The following is a description of a gene set: studied in species Homo sapiens Human Gene Set: GSE25088_CTRL_VS_IL4_AND_ROSIGLITAZONE_STIM_MACROPHAGE_UP Genes up-regulated in wildtype bone marrow-derived macrophages: control versus treated with IL4 and rosiglitazone. C57Bl/6 wild-type and STAT6 KO mice were used to study PPARg and IL-4 signaling. Bone marrow of 3 mice per group was isolated and differentiated to macrophages with M-CSF (20 ng/ml). 20 ng/ml IL-4 was used to induce alternative macrophage activation and 1 uM Rosiglitazone (RSG) was used to activate PPARg. From each mouse 4 samples were generated: 1. M-CSF, 2. M-CSF+RSG, 3. IL-4 and 4. IL-4+RSG. All compounds were added throughout the whole differentiation process, and frech media was added every other day. Control cells were treated with vehicle (DMSO:ethanol). After 10 days, RNA was isolated and gene expression profiles were analyzed using Mouse Genome 430 2.0 microarrays from Affymetrix. from publication Szanto A, Balint BL, Nagy ZS, Barta E, Dezso B, Pap A, Szeles L, Poliska S, Oros M, Evans RM, Barak Y, Schwabe J, Nagy L (PMID 21093321), and this is the list of marker genes: RIOX2, CD44, CDCA7, CXCR3, TSPYL4, CD86, MB21D2, ESD, MED26 (NCBI Gene Id 9441), AQP3, GGT1, CHP2, HSD17B11, ELF4, SLC38A2, RDM1, SSBP2, CLDND1, RDX, FYTTD1 (NCBI Gene Id 84248), ARMCX1, TNFRSF11A, GRK2, COMP, DTX4, IL7R, TBCEL, LINC01904 (long intergenic non-protein coding RNA 1904), COTL1, POLR3G, BIVM, MAMDC2, SNCG, KCNQ5, MICAL2, ID1, RARA, DLST, IL17D, IRAK3, PTK7, TCF7 (NCBI Gene Id 6932), NOD2, SIK1, SVIL, SH2D3A, IL6ST, POGLUT2, HLA-DPB2, ANXA2R-AS1, CD2AP, NAPSB, IRF1, IRF2BPL (interferon regulatory factor 2 binding protein like), GPC6, REL, ADAM9, MALT1, GFRA1 (NCBI Gene Id 2674), SELL, TPBG, RGS16, GZMK, LINC03007, RAB5A, OLIG1, DTX1, CACNG8, CASK, RAB21, KLHL6, EXD2, SINHCAF, SNN, SEC24C (NCBI Gene Id 9632), CEP19, IL10RA, QTRT1, KIT, HLA-DMA, GINM1 (NCBI Gene Id 116254), FAIM2, HECTD1, SPON1, OTOP2, KLK13, SCN9A, GPC2, PRKRA, METAP2 (NCBI Gene Id 10988), OR5AK4P, MYRIP, SCML1, C8orf34-AS1, ILDR2, ZNF764, SPINK4, GNRHR2, TRAF5, CCSER1 (NCBI Gene Id 80730), TARS1, PLP2, ZBTB18, GNAQ, USP19, UBE2Q2, HAMP, SRF, IFRD1, KMT5B, TMEM14C, CNN3, MTMR14, GPR183, FLNB, WFDC21P (NCBI Gene Id 650626), SCHIP1, ZNF711, MAP3K1, KLF14, SCML2, SPINK2, FFAR4 (free fatty acid receptor 4), CPSF6, CCR1, TMEM63A, ATF5, HADHB, RAB3GAP1, PTK2, TOP2A (NCBI Gene Id 7153), TYMS, ZNF330, GAS5, RREB1, SLC18B1, HASPIN, UTS2, KLHL15, ZCCHC3, ZCCHC24, DUSP4, TRRAP, PIK3CA, ZNF704, DPH5, RUNX2, RHBDF1, RASSF2, SETD2, TNFRSF9, WDFY1, MAML2, C1orf127, SPIN3, A1BG, SRSF6, MPZL3, NELFCD, RCAN3, CDR2, HSPD1, CLINT1 (NCBI Gene Id 9685), HIP1, PADI4, TGFBI, MAPK6, BCCIP, DCTN4, ATP8A2, NAA60, ADAMTS14, IFT57, CARD19, ALDH2, BIK, ZNF768 (NCBI Gene Id 79724), HIVEP2, MLXIP, HBS1L, TFE3, DUSP10, FURIN, ARF4, KLHL13, SEMA6B, JHY, CCDC190, SOX4, CCT4, IER3, ANXA7, ATP1B1, CIMIP1, BEX3 (NCBI Gene Id 27018)